The following is a description of a gene set: Catalysis of the reaction: R-CO-X + H2O = R-COOH + HX, hydrolysis of an acyl group or groups from a substrate molecule. Human Gene Set: GOMF_DEACYLASE_ACTIVITY studied in species Homo sapiens, and this is the list of marker genes: PPT2, SIRT4, HDAC11, DTD1, MIER3, ACOT13, HDAC9, ACOT7, ACOT4, ACOT12, SKI, HDAC7, DESI1, ACOT11, SIRT1, ACAA2, MACROD2, HDAC4, HDAC8, ACOT8, SIRT7, PIGL, SIRT6, PPT1, HDAC3, ACOT2, MIER1 (MIER1 transcriptional regulator), NDST4, HADHA, HDAC10, THEM5, SUDS3, ABCD2, PLA2G6, TP53, MACROD1, NDST1, HDAC5, HDAC6, UCN, ING2, CES2, MIER2, DTD2 (NCBI Gene Id 338013), ESD, THEM4, HOPX, ENSG00000293349, PGAP1, SIRT5, SIRT3, DESI2, ABCD3, NDST3, YDJC, AMDHD2, SIRT2 (NCBI Gene Id 22933), CES1, ACOT9, HDAC1, CLN5, HIBCH (NCBI Gene Id 26275), NDST2, ACOT6, ADPRS, ABCD1, MAPK8, MBLAC2, AADAC, MTA2, OARD1, HDAC2, ACSBG2, ACOT1, BAAT